Given this list of marker genes FADS2, FADS1, ACOT2, ELOVL2, ELOVL5, ACE2, here is a description of the gene set: Human Gene Set: WP_LINOLEIC_ACID_METABOLISM_AFFECTED_BY_SARSCOV2 studied in species Homo sapiens Linoleic acid metabolism affected by SARS-CoV-2